The following is a description of a gene set: species: Homo sapiens Pancreatic hypoplasia Hypoplasia of the pancreas. Human Gene Set: HP_PANCREATIC_HYPOPLASIA, and this is the list of marker genes: INS, SBDS, GCK, GLIS3, GATA6, RFX6, STAT3, BLK, DNAJC21, ABCC8, PDX1, KLF11, PAX4, EFL1, KCNJ11, APPL1, FOCAD, SLC29A3, HNF1B, PTF1A, HNF1A, HNF4A, CEL, NEUROD1